Given this list of marker genes GTF3C3, GTF3C6, GTF3C2, GTF3C4, GTF3C1, GTF3C5, here is a description of the gene set: Human Gene Set: GOCC_TRANSCRIPTION_FACTOR_TFIIIC_COMPLEX A heterotrimeric transcription factor complex that is involved in regulating transcription from RNA polymerase III (Pol III) promoters. TFIIIC contains three conserved subunits that associate with the proximal Pol III promoter element, and additional subunits that associate with sequence elements downstream of the promoter and are more diverged among species. It also functions as a boundary element to partition genome content into distinct domains outside Pol III promoter regions. studied in species Homo sapiens